The following is a description of a gene set: T cell dysfunction is an important feature of many chronic viral infections. In particular, it was shown that PD-1 regulates T cell dysfunction during chronic LCMV infection in mice and PD-1 high cells exhibit an intense exhausted gene signature. These findings were extended to human chronic infections such as HIV, HCV and HBV. However, it is not known if PD-1 high cells of healthy humans have the traits of exhausted cells. In this study, we provide a comprehensive description of phenotype, function and gene expression profiles of PD-1 high versus PD-1 low CD8 T cells in the peripheral blood of healthy human adults as following: 1) The percentage of naive and memory CD8 T cells varied widely in the peripheral blood cells of healthy humans and PD-1 was expressed by the memory CD8 T cells. 2) PD-1 high CD8 T cells in healthy humans did not significantly correlated with the PD-1 high exhausted gene signature of HIV specific human CD8 T cells or chronic LCMV specific CD8 T cells from mice. 3) PD-1 expression did not directly affect the ability of CD8 T cells to secrete cytokines in healthy adults. 4) PD-1 was expressed by the effector memory (TEM) compared to ‘terminally differentiated effector’ (TEMRA) CD8 T cells. 5) Finally, an interesting inverse relationship between CD45RA and PD-1 expression was observed. species: Homo sapiens Genes down-regulated in comparison of PD-1 high CD8 T cells versus PD-1 low CD8 T cells. Human Gene Set: GSE26495_PD1HIGH_VS_PD1LOW_CD8_TCELL_DN from publication Duraiswamy J, Ibegbu CC, Masopust D, Miller JD, Araki K, Doho GH, Tata P, Gupta S, Zilliox MJ, Nakaya HI, Pulendran B, Haining WN, Freeman GJ, Ahmed R (PMID 21383243), and this is the list of marker genes: GPER1, CCDC196, FAM47C, FOXD1 (NCBI Gene Id 2297), FRY, BCL2L2, HOPX (NCBI Gene Id 84525), IQCG, GLP2R, PARPBP, IER5L, LIMCH1, PITPNM2, TBC1D25, TWSG1, BOK, CTBP2 (C-terminal binding protein 2), ASPN, PDXDC2P, PLXNA4, BLZF1, SERPINB4, C4orf54, CES1, GOLGA4-AS1, ITGB1 (NCBI Gene Id 3688), ARHGAP42, ADCY9 (NCBI Gene Id 115, adenylate cyclase 9), USP47, ATL1, ASPDH, AADACL2, FOXN3-AS1, ITGAX, CPSF4, SH2D1B, SNHG33, KIR2DL2, RPL14, USP3, RXRA, ZNF670, SPECC1, CRNDE, TENT5A, PDZK1, JAKMIP2, VNN1, TSHZ3, TM6SF1, DNM3OS, KLRC4, KIR3DL3, MXD1, MIX23P3, NGFR, BNC2, CREB5, AVEN, RGS17, NOTCH1, CMKLR1, RASSF4, LY6H, PYROXD2, DRAXIN (NCBI Gene Id 374946), C14orf28, ATP8B4, ADGRG5, PSEN2, KLRD1, DSG1, PROX2, NDRG2, ARB2A, TYROBP, GNGT1, AKT1S1, HOXC4, NCR1, GOLGA7B, HDHD5-AS1 (HDHD5 antisense RNA 1), KIR2DL5A, LDHD, CXCR2, LPGAT1, DSTN, KIR2DS2, HSH2D, MAGI2, MCPH1-AS1, FRMD6, ACVR2A, C9orf43, KLF8, NCAM1, GNLY, CENPS, PRSS30P, STX8, NME8, C17orf58 (chromosome 17 open reading frame 58), TMEM184B, ATXN3L, HMCN1, FAR2P1, ZBTB22, TTC38, TNFSF12, LYN, KIR2DL3, TSPAN32, ZMAT3 (NCBI Gene Id 64393), ZNF789 (NCBI Gene Id 285989), H4C6, MTMR11, ITGAM, NCALD, ACOT7, ASCL2 (NCBI Gene Id 430), CYP7A1, SEPTIN7, CT75, HMOX1, TJP2, SCLT1, LINC00917, KIR3DL1, KIR2DS5, HOXA10, KIR2DS1, COLGALT1, TENM1, ARRB1, CFAP263, LRRCC1, PIK3AP1, TSPAN2, SMIM3, STS, MAGEF1 (NCBI Gene Id 64110), TMCC3, FCGR3B, PLCG2, PRKACB, SYNGR1, CARNS1 (carnosine synthase 1), GAS7, OSBPL5, CIMAP2, ANO7L1, MXRA7, SERPINF2, COL24A1, CD320, RUNDC3B, ATP6AP1L, UBE2F, KIR2DS4, F12, MCTP2, PDE4A, IFITM1, SIGLEC17P, ADRB1 (NCBI Gene Id 153), KLRC3, TSPAN12, MAGEE1, LAT2, LPP, DCX (NCBI Gene Id 1641), STYK1, SLCO4C1, TLR4, AGPAT4, CHRNB1, RAB23, KLRF1, GLUL, DUSP22, EIF4EBP2, ADAM8, ABHD2, NQO1, KATNAL2, S100A2, RRBP1, TMT1A (thiol methyltransferase 1A), GPR153, FAM83C